The following is a description of a gene set: Human Gene Set: GOBP_MEMBRANE_FISSION species: Homo sapiens A process that is carried out at the cellular level which results in the separation of a single continuous membrane into two membranes., and this is the list of marker genes: CHMP3, EXOC5, CHMP6, SPAST, VPS4A, SNF8, VPS28, DNM1L, CHMP5, CHMP7, CHMP4A, TMCC1, EXOC4, STAM2, EXOC1, TSG101, HGS, SH3GLB1, VPS37C, CHMP2A, DNM1, EXOC3, UBAP1, CORO1C, CHMP1A, VPS37A, VPS37B, EXOC8, EXOC2, VPS36, CHMP2B, VPS37D, DNM2, STAM, CHMP4B, SLC25A46, VPS4B, CHMP1B, EXOC6B, EXOC6, MVB12A, CHMP4C, MVB12B, VPS25, EXOC7